Given this list of marker genes PRKAR2A, P2RX7, EXT1, PTK2B, XRCC5, TNFAIP1, ABLIM1 (actin binding LIM protein 1), CHD7, GGCT, JARID2, HIF1A, FLVCR1, CD81, ETS1, LIMA1, RAPGEF2, TMTC4, GPM6B, BIVM, NFIL3, PHLDA1, BAG3, SLA, CD27, MAGED1, CORO2A, AAK1 (NCBI Gene Id 652453), TIMP2, SDC1, FAM107B, ARRB2, EGLN3, FBXO38, ZMYM4, EPDR1, SYT14, DZIP1, LRIG1, UBL3, NFKB1, EVL, CTNND1, TULP4, HECTD2, SESN3, CD28, IQCH, RGS10, NBEAL1, MAP3K4 (NCBI Gene Id 4216), NEU3, KLF11, GIMAP7, MKRN1, ST3GAL2, ZDHHC13, SKIL, SH3KBP1, HERC1, NDFIP1, ACOX1 (NCBI Gene Id 8308), CENPV, USP33, SYT13, ZSWIM6, PPP1CC, PXYLP1, LMCD1, SRGAP2, TOX (NCBI Gene Id 9760), C19orf38, ACAA2, IGFBP4, RAPGEF6, CLOCK, ADGRE5, PSPH, DTX1, SHISA5, EFEMP2, LRRC66, SMAD3, MYO1E, CD5, CHCHD3 (NCBI Gene Id 54927), DENND6A, CDC25C, ZAP70, SPRED2 (NCBI Gene Id 200734), ENO1, CASP8, ARHGEF3, ABI2, HEG1, LBH, IKZF1, TMEM101, CD82, FRMD4B, FKRP, DUSP10, IRF4, KCNIP2, RBM3, AXIN2, FUT10, HASPIN, CAMSAP2, SERTAD4, SLAMF6, PTPN13 (protein tyrosine phosphatase non-receptor type 13), TRIB2, HIVEP2, DNAJB4, ITGB2, MBOAT2, PLCL1, DOCK9, RASA2, SH3RF1, TMSB10, RASGRP1, IKZF2, LEF1, ADAM19, GOT1, PTPN14, SLC35G1, DST, DUSP22, EGR1, DPP4, BTLA, FJX1, LY9, LPCAT1, DNMT3A, SEMA7A, RFX3, TTC3, KCTD6, CDH10, TINF2, ARHGAP12, BMP7, IKZF3, MFHAS1, RNF125, FGF13, PITPNM2, METTL6, AGFG1, F2 (coagulation factor II), RELL1, PDGFRB, TMEM161B, CCNG2, CD2, SFMBT2, SBF2, SSH2, FYN (NCBI Gene Id 2534), PRKD2, PRMT7, ANO10, MBNL2, GIMAP4, UACA, SLC28A2, RCBTB1, ITM2A, LIPA, IL6ST, JAK2, CCR4, GFRA1 (NCBI Gene Id 2674), SLC11A2, PRKCQ, DRAM2, PARM1, here is a description of the gene set: species: Homo sapiens Genes down-regulated during B lymphocyte differentiation: large pre-B II versus VPREB1+ pre-B Il. from publication Hoffmann R, Lottaz C, Kühne T, Rolink A, Melchers F (PMID 17890238) Human Gene Set: GSE4590_LARGE_PRE_BCELL_VS_VPREB_POS_LARGE_PRE_BCELL_DN Cells from four develppmental stages were purified by FACS from human bone marrow samples